Given this list of marker genes IKBKG, IRAK1, PELI3, UBE2V1, IKBKB, PELI2, CHUK (component of inhibitor of nuclear factor kappa B kinase complex), UBA52, UBE2N, RPS27A, PELI1, UBC, UBB, TRAF6, here is a description of the gene set: IRAK1 recruits IKK complex Human Gene Set: REACTOME_IRAK1_RECRUITS_IKK_COMPLEX species: Homo sapiens